The following is a description of a gene set: Human Gene Set: HP_OPTIC_NERVE_COMPRESSION species: Homo sapiens Optic nerve compression, and this is the list of marker genes: USP48, TMEM53, TNFRSF11A, TGFB1, CA2, BRAF, SNX10, USP8, ATRX, TNFSF11, TCIRG1, CDH23, CLCN7, TP53, NR3C1